Given this list of marker genes TRAPPC2, RSPRY1, PRG4, TRPV4, RAB33B, GLB1, COL2A1, here is a description of the gene set: Human Gene Set: HP_FLATTENED_FEMORAL_HEAD species: Homo sapiens An abnormally flattened femoral head. Flattened femoral head